The following is a description of a gene set: Human Gene Set: GSE6269_HEALTHY_VS_STAPH_PNEUMO_INF_PBMC_UP from publication Ramilo O, Allman W, Chung W, Mejias A, Ardura M, Glaser C, Wittkowski KM, Piqueras B, Banchereau J, Palucka AK, Chaussabel D (PMID 17105821) studied in species Homo sapiens Each infectious agent represents a unique combination of pathogen-associated molecular patterns that interact with specific pattern-recognition receptors expressed on immune cells. Therefore, we surmised that the blood immune cells of individuals with different infections might bear discriminative transcriptional signatures. Gene expression profiles were obtained for 131 peripheral blood samples from pediatric patients with acute infections caused by influenza A virus, Gram-negative (Escherichia coli) or Gram-positive (Staphylococcus aureus and Streptococcus pneumoniae) bacteria. Thirty-five genes were identified that best discriminate patients with influenza A virus infection from patients with either E coli or S pneumoniae infection. These genes classified with 95% accuracy (35 of 37 samples) an independent set of patients with either influenza A, E coli, or S pneumoniae infection. A different signature discriminated patients with E coli versus S aureus infections with 85% accuracy (34 of 40). Furthermore, distinctive gene expression patterns were observed in patients presenting with respiratory infections of different etiologies. Thus, microarray analyses of patient peripheral blood leukocytes might assist in the differential diagnosis of infectious diseases. Genes up-regulated in comparison of peripheral blood mononuclear cells (PBMC) from healthy donors versus PBMC from patients with acute S. pneumoniae infection., and this is the list of marker genes: MXD4, MADD, PRR5L, MIA3, ACAP1, ABCD4, PTPN4, CPSF4, DCTD, PLEKHF1, SLC25A5, CCR6, BIN1, OGFOD2, IRF8, PSMB9, IGHV5-78, RASSF1, DNASE1L3, GTF2H5, RBM4, MTHFD1, BTN3A1, SPDL1, NCALD, SNTB2, SEC13, CCR9, OARD1, ADGRG1, ZNF506, GTF2H2, CKS1B, POGLUT1, C1orf50, TMCO6, AKAP17A, AHSA1, CBLB, ZNF135, TFB1M, MYBBP1A, DDX54, DIDO1, NEK1, RXYLT1, ILKAP, BORCS6, ZNF91, SP110, KLF3-AS1, EFL1, PRDM10, DNAJC16, ASCC1, DZIP3, CMTR1, ADA, PLA2G6, CSNK1D, TMEM63A, HCP5, DPH5, SAFB, CHST12, PDHB, UPF1, MIPEP, CLN8, PPP2R2B, KRBOX4, PRKD2, ARHGAP25, NASP, POLG, ARHGAP45, ITFG2, INPP5D, TMEM268, JAK1, POLR2G (RNA polymerase II subunit G), EZH1, SFI1 (SFI1 centrin binding protein), WRN, LUC7L, ETAA1, KLRK1, GEMIN4, PTCD3, ACYP1, NSUN5, TARS2, HTRA2, PWWP3A, LILRA4, WDR59, PRF1, AGAP4, USP11, ABCB1, PAN2, CEP83, SGSM3, PGGHG, FH, PRSS23, NPC1, PPM1G, SNRNP35, PRKCH, TTC4, UPF3B, HIF1AN, RBM5 (RNA binding motif protein 5), PSD4, ZBP1, EXOC7, NSUN5P1, NEK9, NT5C, TBC1D31, HS3ST1, C1orf174, PHF20, ADSL, RLN1 (NCBI Gene Id 6013), AIP (aryl hydrocarbon receptor interacting protein), TSR1, CHKB, GZMB, IVD, RAD51C, ZBTB40, XCL1, TMEM97, LONP2, CCT4, RFC4, TNPO2, ZNF514, DKC1, MTSS1, HIVEP2, TCP1, PBXIP1, PRORP, EIPR1, EXOSC7, SBF1, ESYT1, PIGG, AKT3, FNBP1, NUMA1, POLR2M, SLC25A38, UBE2D2, GLG1, NUP85, IL16, SLC5A3, NFATC2IP, MOCS2, BTN3A3, SLC25A17, ING4, EIF2B5, CIAO1, RANBP3, NHERF1, OCM2, ZBTB14, CUL4A, ZMYND11, EPM2A (NCBI Gene Id 7957), STARD7, RASGRP2, ARL6IP4, CCT7, TAF1B, POLR2H (RNA polymerase II, I and III subunit H), GOLGA8A (NCBI Gene Id 23015), SEC24C, SUGP2, EIF5B, TRAPPC4, SUN2